The following is a description of a gene set: A small subcellular vesicle, surrounded by a membrane, that is formed from the Golgi apparatus and contains a highly concentrated protein destined for secretion. Secretory granules move towards the periphery of the cell and upon stimulation, their membranes fuse with the cell membrane, and their protein load is exteriorized. Processing of the contained protein may take place in secretory granules. species: Mus musculus Mouse Gene Set: GOCC_SECRETORY_GRANULE, and this is the list of marker genes: Defa34, Defa26, Fndc3a, Lyzl4, Arpc2, Plat, Prss57, Rnd2, Gip, Elane, Itgb1, Vps13b (vacuolar protein sorting 13B), Spink5, Fgg, Trh, Ncf2, Rab2a, Klk9, Atp6v1a, Defa25, Prss51, Abca12, Sftpc, Oxt, Prss40, Sprr2i, Reg3g (NCBI Gene Id 19695), Itpr1 (NCBI Gene Id 18544), Tmprss12, Spag6l, Hyal5, Nppc, Sprr2g, Cypt1, Arsa, Catsper3, Napsa, Spesp1, Clcn3 (NCBI Gene Id 12725), Abcc4, Cdc42, Lamp3, Cma1, Actl7a, Pkdrej, Myo5c, Pcsk4, Itpr3, Ins2, Defa23, Klk7, Defa39, Pate4 (prostate and testis expressed 4), Pam, Tnf, Mmrn1, Tmem190, Cfap65, Arc, Zp3r, Crisp1, Dnase1, Stxbp2, Scamp1, Eqtn, Loxl1 (NCBI Gene Id 16949), Tssk1, Tgfb1, Tmem210, Gnai3, Tmem63b, Capn11, Gnat3, Glipr1l1, Anxa3, Sypl1, Sparc, Cartpt, Resp18, Rab6a, Fstl4, Spaca5, Spata16, Gp2, Igf1, AY761185, Stx3, Ptprn, Gm14569, Unc13d, Adrb2, Ift20, Slc18a1, Stxbp3, Snapin, Lyzl6, Avp, Dennd4c, Slxl1, Txndc8, Dkkl1, Klk1 (NCBI Gene Id 68329), Vamp8, Gck, Dld, Fsip1, Chga (NCBI Gene Id 12652), Hyal3, Plcb2, Snca, Padi6, Slc2a3, Defa5, Dcst2, Capza3, Hps4, Lypd4, Pak2, Pla2g2a, Cep131, Sprr2e, Ece1, Wfs1, Slc18a2, Scnn1a, Mfge8, Hexa, Spx, Acrv1, Rab4a, Exoc3l, Izumo1, Edn1, Tmprss4, Defa38, Baiap2, Lnpep, Vamp2, Dynlt4, Atp6v0a2, Rab7, Cxadr, Abcc9, Rab4b, Calcrl (NCBI Gene Id 99263), Cyp51, Pomc, Klk15, Trim36, Vamp3, Ctnna1, Prss55 (serine protease 55), Actrt1, Thbs2, Gal, Prss39, Klk13, Tgfb2, Dcst1 (NCBI Gene Id 77772), Defa35, Lamp2, Ghrhr, Clip2, Myo5a, Spaca7, Drd2, Pla1a, Iqcf1, Dmxl2, Cfap119, Defa2, Tff3 (trefoil factor 3, intestinal), Angptl6, Krtdap, Fstl3, Serpina5 (NCBI Gene Id 268591), Bace2, Klk1b8, Atp8b5, Klk4, Sycn, Tmed2, Eppin, Spag11a, Tsc22d4, Ly6k, Tmem95, Srgn, Try5, Acr, Pcsk2, Spaca1, Clu, Igfbp3, Ctsh, Pla2g10, Tbxa2r, Thbs1, Selp, Crh, Sprr2a1, Atp8b3, Slc6a5, Slc2a4, Kit, Stxbp5l, Ace3, Kif1a, Spaca3 (NCBI Gene Id 75622), Gh, Akap3, Mroh2b, Atp6v1e2 (ATPase, H+ transporting, lysosomal V1 subunit E2), Klk11, Defa24 (NCBI Gene Id 503491), Rph3a (NCBI Gene Id 70216), Spaca6, Crcp, Lrguk, Rab11fip5, Morn3, Zg16, Bsg, Pcsk1, Morn2, Defa30, Zpbp2, Gars1, Izumo3, Prss37, Snap23, Tmem184a, Ins1, Lyz2, Atp8a1, Adam2, Vps13a, Cav2, Vamp1, Rab10, Golga1 (NCBI Gene Id 99313), F5, Cuzd1, Osbp2, Sun1, Iqub, Atp7a, Ccdc136, Stx7, Syt9, Brca2, Hspd1 (NCBI Gene Id 15510), Prkg1, Klk12, Kcnq1, Col1a1, Npy, Klk1b27, Klk8, Adam8, Septin14, Skil, Spag8, Syt13, Pla2g1b, Akt2, Acp3, Ap2m1 (adaptor-related protein complex 2, mu 1 subunit), Ssh2, Ica1, Hgs, Stx1a, Nudt1, Olfm4, Tcp11x2, Sri, Ctsl, Actn1 (actinin, alpha 1), Hexb, Slc17a9, Usp8, Mpo, Klk10, Chgb, Klk14, Ica1l, Cel, Sod1, Prkaca, Flot2 (flotillin 2), Syt8, Defa41, Fga, Defa17 (NCBI Gene Id 23855), Cimip4, Cct6a, Dnm1, Rnpep, Spaca9, Pla2g4a, Cav1, Ang4, Slc30a5, Syt1, Car4, Stk31, Pdyn, Vps13c, Slc18b1, Ncs1, Calr, Vwf, Nos1 (nitric oxide synthase 1, neuronal), Klk1b16, Abhd2, Anxa4, Klk1b1, Tgfb3, Defa32, Cylc1, Pikfyve, Ebag9, Pdia3, Syt4, Tex101, Gcg, Scg2, Fabp9, Tsks, Npff, Klk6, Rab3b, Dvl1, Cracr2a, Racgap1, Dmd, Fam170b, Stxbp5, Lrp1, Slc6a9, Slc11a1, Vps33b, Klk1b9, Ift88, Defa37, Il1b, Ap2a1, Sftpb, Dbh, Sv2b, Cadps, Calcr, Zpbp, Tcirg1, Rab27b, Itga1, Htr1d, Rab2b, Knl1, Defa3, Rab5a, Omp, Atp2c1, Reg1, Pomt1, Scg3, Tbc1d21, Tmed10, Enkur, Semg1, Ghrl, Gnai2 (G protein subunit alpha i2), Ptprn2, Tssk2, Serpini1, Vezt, Gkn1, Sprr2a3, Adrb1, Slirp, Scg5, Pcsk1n, Defa28, Tssk4, Spaca4, Ltf, Rab26, Crhbp, Pramel1, Cfp, Lamp1, Grp, Fgb, Catsper4, Dpep3, Sst, Creb3l4, Acrbp, Kcnj11, Bpifa2, Spam1, Ccdc62, Defa27, Rab3d, Ppfia3, Adcyap1, Rab27a, Slc30a2 (NCBI Gene Id 230810), Ift74, Klk1b11, Clca1, Rab3a, Serpine2, Camp, Spink2, Anxa11, Defb22, Rab13, Clk3, Syt5, Cacna2d1, Defa43, Ogt, Ecrg4, Scgb1a1, Il4i1, Klk1b4, Bdnf, Ccl28, Treml1, Ct55, Hilpda, Nlrp5 (NLR family, pyrin domain containing 5), Klk1b22, Spag6, Fzd8, Pf4, Tmem225, Ctsg, Serpine1, Hcrt, Itpr2, Cd46, Rab14, Tor1a, Tex22, Prss58, Abca3, Klk1b5, Npy1r, Trip11, Myrip, Adam15, Sh3gl3, Actl9, Klk1b24, Rcbtb2, Tcp1, Spata1, Klk5, Stxbp1, Dynll1, Klk1b26, Dnajb3, Syt2, Slc9a4, P2rx2, Anxa7, Tekt3, Rab37, Tuba8, Defa36, Spag17, Klk1b3, Snx10, Aqp1, Cabs1, Lyz1, Moxd2, Fam220a, Rab12, Defa31, Pnliprp2, Csnk2a2, Rph3al, Spata31, Notch1, Defa40, Prss59, Sytl4, Exoc3, Smpd1, Cyb561, Slc30a8, Tcp11, Stx4a, Slc9a8 (solute carrier family 9 (sodium/hydrogen exchanger), member 8), Prl (prolactin), Ppbp, Syt7, Cbarp, Vegfa, Cpe, Reg3b, Klk1b21, Calca, Myh9, Sprr2d, Oprd1, Fas, Defa42, Dnajc5, Bmf, Astl, Cd177, Moxd1, App, Itgb2l, Dmbt1, Defa20, Cabp1, Prtn3, Vdac2, Ap2a2, Penk